The following is a description of a gene set: Abnormality of the philtrum Human Gene Set: HP_ABNORMALITY_OF_THE_PHILTRUM studied in species Homo sapiens An abnormality of the philtrum., and this is the list of marker genes: BBS5, SETD5, LRRC32, ZNF699, RUNX2, PIGN, AHDC1, CCDC8, ERCC6, WDR4, MAPRE2, ABCC9, COL3A1 (NCBI Gene Id 1281), JARID2, FAR1, FGD1, JMJD1C (NCBI Gene Id 9323), SPRED2 (sprouty related EVH1 domain containing 2), TTC5, MRPS28, BMP1, DNAJC30, CNTNAP2, TBR1, NAA20, KCNJ11, ARSK, PGAP2, LEMD2, CHAMP1, IFT57, DYM (NCBI Gene Id 54808), RERE, AASS, MYOD1, FGFR2, ADSL, OPHN1, IFT80, NUP107, SCLT1, COX7B, TAF1 (NCBI Gene Id 6872), SMARCA2, IFIH1, SLF2, HRAS, EXT1, TOE1, IL6ST, TRIM32 (NCBI Gene Id 3971), PCLO, DHCR7, CEP290, MMACHC, MAPK8IP3, MADD, NBN, SPECC1L, COG3, BBS4, TMCO1, FLNA (filamin A), GNB1, KMT2A, GABBR1, DYRK1A, TSPAN7, C1GALT1C1, HNRNPH2, CTBP1, RFC2, DEAF1, B4GALT1, EXOSC1, TRMT10A, MYCN, PSMC3, YARS2, IRX5, COL11A1, PCDHGC4, PTCH1, PTPRF, KCNJ8, LZTFL1, TBL1XR1, TMEM94, KIT, SHH, NF1, TET3, UPF3B, EPG5, KDF1, BAP1, DOCK7, MAB21L2, SLC2A1, UNC80, UBAP2L, C12orf57, AFF4, WNT4, CDK10, PTEN, PIGG, XYLT1 (NCBI Gene Id 64131), ACTB (actin beta), FKBP6, BBS2, NELFA, GJA5, POLR3A, CDH11, ARID1B, UBE4B, SUFU, COLEC11, AP1S2, SMARCB1, ERMARD, SYT1, GLIS3, PACS1, SUZ12, RAD21 (RAD21 cohesin complex component), TAOK1, EPB41L1, RECQL, DLL3, SOX11, KLHL41, ALX4, DHX9, MAP2K1, FBN1, ZIC2, ELN, BCR, DYNC2I2, MPC1, USB1, MESP2, KCNAB2, SPTBN1, MID2, FIG4, PIGL, HMBS, GPC6 (glypican 6), FBXO11, PRDM16, KRAS (NCBI Gene Id 3845), FGFR1, OCRL, GMPPA, PUS1, TFAP2A, TMEM147, SNX14, GRIA4 (glutamate ionotropic receptor AMPA type subunit 4, NCBI Gene Id 2893), NR4A2, TRAPPC4, ADNP, MAB21L1, BCL11B, BCKDK, UBE2A, FOXG1, RAB18, PRDX1, LIMK1, CHD2, ACTG1, ATRX (NCBI Gene Id 6475), TOR1A, SYNE1, BBS9, EXOC7, PIGA, OSTM1, HIVEP2, PUF60, ATN1, ABL1, SON, MAPK1 (mitogen-activated protein kinase 1), BRAF, H4C5, TMEM53, ZNF462, FGF3, PURA, RFX7, POGZ, CRELD1 (cysteine rich with EGF like domains 1), PGAP3, DDX6, DIS3L2, MAP2K2, MID1, EIF4H, TRIP12, CRIPTO, ZEB2, TBCK, CUL4B, DVL3, SUMF1, THSD1, TGIF1, PIEZO2, KDM5A, HIRA, PKDCC, KIF7, CHD5, PSMD12, MYMX, KDM5B, TPM3, HOXB1, BAZ1B, MAGEL2, TRPS1, BBS12, CRTAP, UBR1, MOCS1, WBP4, NSD1, ACER3, MARS2, DISP1, TWIST1, PPP2R3C, DPM1, PHF21A, KDM4B, CDH2, NSUN2, VPS37D, PLPBP, MED25, HSPG2, RREB1, BUB1B, TRAPPC9, UBE3B, ATP6V1B2, SLC9A7, MEIS2, GTF2IRD1, COMT, PIGS, IDH1, NBAS, ATP7A, RYR1, NFIX, KAT6B, TUBB, MYH3, LMX1B, LARP7, CAMTA1, CDKL5, FGFRL1, PAM16, DVL1, KCNH1, SEC24C, MEGF8, FOXL2, COL11A2, TASP1, FREM1, PBX1, CSGALNACT1, STX1A, SCAPER, AP3D1, PRMT7 (NCBI Gene Id 54496), MYH8, LMNB1, SMC3, BBIP1, KCNK4, NCF1, POU4F1, PIGO, WWOX, TRIM8, CASZ1, TMLHE, HDAC6, NALCN, MOCS2, ATP6V1E1, GP1BB (NCBI Gene Id 89199), BPTF, COG7, CPLX1, FZD2, PGM2L1, IFT74, CLTC, PRKACB, CHST3, SHANK3, METTL27, CD96, SLC6A1, AP2M1, COG8, SCN1A, EBF3, PRKDC (protein kinase, DNA-activated, catalytic subunit), H4C11, CLIC2, SIN3A, RIPPLY2, PIGQ, DHPS, MEG3, LFNG, AFF3, SMC1A, IFT140, HNRNPU (NCBI Gene Id 3192), GTF2IRD2, ESAM, KIAA0753, CASK, KDM6A, PDPN, RAI1, AP4S1, ALDH6A1, KIFBP, KIF15, SATB1, INTS1, DPF2, TBL2, SRCAP, ZDHHC9, EZH2, GTF2I, PRKACA, ACTA1, ASH1L, KCNK9, DPYSL5, RALA, H3-3B, PTH1R, CDON, RIC1, SIX3, PLAA, RPL10, BBS10, ATG7, PIGW, BRF1, PAH, NEK9, AUTS2, EBP, NECTIN1, NARS2, RNF135, TPR, NEXMIF, ZBTB18, EDEM3, HDAC8, TBC1D24, ARX, ZNF292, UBR7, RAP1GDS1, HUWE1, EXOSC2, ERF, STAG2, SH3PXD2B, ARVCF, METTL5, STXBP1, ADAMTSL2, RAC3, SCN4A, BRPF1, INPPL1, ARID1A, SDCCAG8, SATB2, PPP1R21, SYNGAP1, OBSL1, TUBGCP2, IFT81, ARNT2, ARHGEF2, ITPR1, ANO1, GRIA3, FILIP1, WDR35, ZC4H2, LETM1, CLIP2, VAC14, IGF1R, MYMK, PITX2, GATAD2B, MYO18B, STEEP1, WDR26, FLII, NOVA2, KIDINS220, PYCR1, SC5D (sterol-C5-desaturase), HPDL, DSE, CFAP418, NIPBL (NCBI Gene Id 25836), THOC6, PIGV, ABCC8, RNU4ATAC, HES7, FAT4, ORC4, COG1, OTUD6B, LTBP3, CHRNG, DYNC2H1, DNMT3A, WNT5A, CKAP2L, TXNL4A, VPS13B (NCBI Gene Id 54990), B3GLCT, GJA1, MLXIPL, WDR19, ROR2, SOX9, PHIP, STIM1, NSD2, LRP4, NRAS, WDPCP, CEP295, FLI1, LZTR1, MEF2C, RAP1B, PPP2CA, B3GALT6, BCAS3, FRA10AC1, ZFX, FOXP2, TNPO2, EIF4A2, BBS7, GAS1, CUL7, MED12, EXOC2, PIGB, MMP23B, NLRP1, GLI2, GNB2, PDE4D, CCBE1, CNOT1, NONO, TTI1, PIGT, ATP6V1A, BMP4, CCNK, CTCF, EFTUD2, ARID2, NXN, PDGFRB, RAB3GAP1, RIN2, SPIN4, EIF2S3, MTX2, BCOR, DDX59, BUD23, PMM2, DLL1, DYNC2I1, SMAD4, SCAF4, POLR3GL, BMP2, KAT6A, PARS2, ANKRD11 (NCBI Gene Id 92821), IQSEC2, BRCC3, PDHA1, TAF4, SLC35A1, CHSY1, MED13, PPP1CB, PQBP1, UGDH, CHST14, SLC45A1, PPP3CA, MSL3, PRIM1 (NCBI Gene Id 5557), GOLGA2, GABRD, SLC35C1, CNOT3, DLK1, MAP1B, MUSK, IREB2, CDK13, DPM2, EXTL3 (exostosin like glycosyltransferase 3), TENM3, HS2ST1, TALDO1, ZNF148, FBXL4, MKS1, COL2A1, CSNK2B, AVP, SPEN, UFD1, ADAMTSL1, ALG12, PPP2R5D (NCBI Gene Id 5528), WDR37 (WD repeat domain 37), FGF8, NSRP1, SLC4A10, SMOC1, AP1G1, CDC42BPB, CDC42, ROBO1, POR, GJA8, PIGY, TRPM3, EP300, ALG11, PIGU, UGP2, BRAT1, ATP6V0A2, AP4B1, THUMPD1, ATP9A, TBC1D20, TGFB3, OCLN, DENND5A, RTL1, TRIO, IFT172 (intraflagellar transport 172), CLCN6, ANTXR1, SRRM2, ANKRD17, ARL6, SKI, EXT2, MGP, RNU4-2, BRD4, SMARCD1, SOX4, SLC26A2, MAN1B1, ZMIZ1, VPS51, SMARCE1, TCF4, TNNI2, TFAP2B, ACBD6, TMEM70, ADAMTS3, LTBP4, NAA10, DHX30, SEC23A, FOXH1, EFEMP1, OFD1, CAMK2G, SLC35A2, PEX26, IFT27, PAX3, ALG13, SETBP1, SMARCC2, GNE, TMEM237, MGAT2, MAF, APC, KIF26A, SHMT2, MTOR, AP4M1, TRIP11, METTL23 (NCBI Gene Id 124512), KARS1, KCNJ6, H3-3A, SMARCA4 (SWI/SNF related, matrix associated, actin dependent regulator of chromatin, subfamily a, member 4), GLB1, DDR2, DHX37, TBX1, TRRAP, TCF3, LUZP1, RHOBTB2, ALG9, IARS2, AP3B1, EMC1, DBR1, CCDC22, CERT1, SLC2A10, GAD1, ZPR1, LTBP1, KMT2D, NODAL, TAF6, SLC25A24, HNRNPC, CREBBP, CEP19 (centrosomal protein 19), TMEM270, TTC8, ERLIN2, NOG, TBCE, RNF2, SHOC2, SMG8, PIK3CA, PYCR2, NKAP, ITCH, PPP1R15B, GALNT2, NOTCH3, CRKL, DPYD, NFIB, BBS1, KDM5C, TWIST2, MCTP2, WLS, MAP3K7, CTNNB1, AARS1, NRCAM, RAB3GAP2, CLCF1, WARS2, KIF11, CRLF1, SNRPB, CLCN3, QRICH1, SKIC3, ALG8, SNAI2, H4C9, U2AF2, TAF8, TBX5, TCTN3, HSD17B4 (NCBI Gene Id 3295), NOTCH2, SMPD4, XYLT2, FLCN, NPHP1, PDCD6IP, SMS, PUS7, HECTD4, CBL, B3GAT3, POC1A, AP4E1, GNPTAB, NEB, PRKCZ, ERCC1, MED12L, SPOP, CDC6, CANT1, RTTN, USP9X, CHD8, SLC6A17, MKKS, PPP1R12A (NCBI Gene Id 4659)